Given this list of marker genes GCNA, RHOG2P, PABPN1P1, CHIC1, SLC16A2, NUTF2P7 (NCBI Gene Id 100291614), RNU6-867P, RPSAP14, RNA5SP507, AWAT1, UHRF2P1, PABPC1L2B (poly(A) binding protein cytoplasmic 1 like 2B), PDZD11, RAB41, RPL7P53, RNU6-562P, DGAT2L6, FTX, SEPHS1P4, ITGB1BP2, ENSG00000284391, RTL5, RNU2-68P, MTCYBP31, RN7SL388P, ZDHHC15, BRAFP1, MIR374C, MIR374A, HDAC8, PJA1, SNX12, FAM236C, RN7SL581P, MAP2K4P1, RLIM, RN7SL648P, DLG3, KIF4A, PABPC1P3, AARSD1P1, ARL5AP5, CDX4, FAM236D, LNX2BP, SNORD3E, ERCC6L, ZCCHC13, ENSG00000283599, TEX11, AWAT2, SOCS6P1, RAB11FIP1P1, PABPC1L2B-AS1, NONO, CAPZA1P3, RPS4X, LINC00891 (long intergenic non-protein coding RNA 891), ZMYM3, RPS23P8, STARD8, GJB1, DMRTC1, PHKA1, GDPD2, MIR545, TTC3P1, IGBP1, RNU1-112P, CXorf65, CXCR3, RPS26P11, PABPC1L2A, TRAPPC2LP1, XIST, MMADHCP1, PCNPP4, ZCRB1P1, MAGEE2, NEXMIF, ARR3, RNU6-1078P, FOXO4, NAP1L6P, MATR3P1 (NCBI Gene Id 100499496), CITED1, TPT1P15, UPRT, LDHBP2, RNY4P23, HNRNPA1P25, HMGN1P35, LINC00269, RPL31P63, P2RY4, ACTR3P2, THAP12P1, INGX, TSIX, FAM236A, FAM226B, TERF1P7, RNU6-245P, OGT, RNU6-330P, MTND4P31, ABCB7, CXorf49B, MIR374B, LRRFIP2P1, JPX, TOMM20P4, CYCSP43, FOXN3P2, PBDC1, IL2RG, MAGEE1, MED12, BUD31P2, TRAPPC13P1, RNU4-81P, IGBP1-AS1, SLC7A3, CNOT7P1, CXorf49, ENSG00000291017, RN7SL790P, WASHC3P1, ENSG00000231963, NLGN3, BMP2KL, MIR421, NALF2, ENSG00000273788, ATP5MKP1, NHSL2, EFNB1, FXYD6P3, PHKA1-AS1, EDA, MORF4L1P6, FAM236B, YWHAZP8, RNA5SP508, SERBP1P1, RNU1-56P, SHISA5P2, RPS6P26, IGBP1-AS2, NAP1L2, DDX3P1, RPS7P14, SAR1AP4, RNU6-1044P, DLG3-AS1, DDX3P2, OTUD6A (NCBI Gene Id 139562), MKRN5P, TAF1, MIR676, RPL21P134, PIN4, SOCS5P4, DMRTC1B, COX6CP12, here is a description of the gene set: studied in species Homo sapiens Human Gene Set: chrXq13